The following is a description of a gene set: species: Homo sapiens Human Gene Set: REACTOME_APOPTOTIC_FACTOR_MEDIATED_RESPONSE Apoptotic factor-mediated response, and this is the list of marker genes: XIAP, C1QBP (complement C1q binding protein), MAPK1, CASP3, CYCS, CASP7, CASP9, CARD8, BAK1, MAPK3, GSDME, GSDMD, AVEN, CDKN2A, DIABLO, APAF1, APIP, UACA, BAX, SEPTIN4